The following is a description of a gene set: The process in which a relatively unspecialized monocyte acquires the specialized features of a multinuclear osteoclast. An osteoclast is a specialized phagocytic cell associated with the absorption and removal of the mineralized matrix of bone tissue. Human Gene Set: GOBP_MULTINUCLEAR_OSTEOCLAST_DIFFERENTIATION studied in species Homo sapiens, and this is the list of marker genes: TNFRSF11A, CD81, DCSTAMP, TCTA, SBNO2, SH3PXD2A, BBLN, CD109, OCSTAMP